Given this list of marker genes FAM78A, DLC1, VDR, ID1, IGFBP4, SH3BP2, TRAPPC14, CHST11, CDK17, CRTC3, AGAP3, STX6, COQ2 (coenzyme Q2, polyprenyltransferase), ZNF710, GNB4, BRPF3, RUNX3, TMCC3, FURIN, TNFAIP8L1, TLE3, MAPKAPK5-AS1, DCBLD1, NFKBIE, PLEKHO2, TYRO3, SMURF2, ELL2, ENG, HIVEP3, TOR4A, TLR1, KCNMB1, ZNF691, SPAST, PIK3C2B, BCOR, TBC1D16, ZSWIM6, SWAP70, ITPKB, SLC22A4, PMEPA1, CBFB, SAMD1, MYO1F, S100A10, FLOT1, SERTAD1, UAP1, RYBP, RIN3, SSH1, GAL3ST4, RELT, SLCO2B1, INPP5A, RASSF5, C10orf95-AS1, GNA13, PSME4, KCNN4, LHFPL2, IL21R-AS1, KDM7A, SLC25A19, IDS, ANGPTL4, PLEKHA7, LAT2, RFX2, VASH1, SKI, CEBPA, MAP1S (microtubule associated protein 1S), CD58, DNASE2, PMPCA, XPOT, CRACDL, ARAP3, SFMBT2 (Scm like with four mbt domains 2), MIR23AHG, TGIF1, MEF2A, FMNL3, CERK, HAVCR2, RGS1, IER5L, NRIP1, TSKU, THBS1, CALHM2, BLMH, NOTCH1, GRB10, SLC46A2, SEMA4B, ARHGEF40, GTF2IRD1, FAM53B, IER2, SLC16A6, ITGA5, SMAD7, ID3, SIGLEC9, SERPINE1, JUNB, ITPRIPL2, TNFRSF12A, ARF6, CAMSAP1, CCDC9B, SLC7A7, LPIN2, MAST3, BTG1, RNF168, KCTD10, OLR1, PLK3, RUNX2, BMPR2, GPR157, TMEM51, TMEM52B, ISCU, SLX4, OTULIN, TRIM36, CYP19A1, ITGAV (NCBI Gene Id 7449), SLC43A2, ZMIZ1, MIR155HG, TMEM223, DUSP1, NEK6, ICOSLG, REST, DESI2, SPIN1, IER3, CXCR4, RGS19, HMOX1, SH3BP4, GPRIN3, SOCS6, RNF166, RFFL, JPT1, RASGEF1B, FHOD1, ZBTB4, MAEA, SKIL, WNT5A, NCOR2, MORC3, TFEB, CXXC5, LFNG, MAP3K2, DENND3, KLF10, NFKBIA, CHD9, PHC2, ELF4, LCP2, LIMS1, SH3GL1, SH3TC1, RCC2, YWHAH, STK40, CEP170 (centrosomal protein 170), NOL4L, LINC-PINT, SPIN4, ID2, MOAP1 (modulator of apoptosis 1), FBXL14, FHL3, NCOA4, BLOC1S2, FAM120AOS, ELK3, APBB1IP, SMAD6, MMP2, SLC7A5, ZRANB1, IRF2BPL, VSIG10L, here is a description of the gene set: Human Gene Set: GSE16266_CTRL_VS_LPS_STIM_MEF_UP To clarify inflammatory genes whose expression is suppressed at high temperatures, we performed comprehensive analysis of gene expression by using a DNA microarray. Two independent primary cultures of mouse embryo fibroblasts (MEF1 and MEF2) were treated with LPS for 4 hours, or treated with LPS for 4 hours after the pretreatment with heat shock at 42˚C for 1 hour, and we identified genes that undergo more than a 3-fold increase with LPS treatment. Remarkably, genes (86%) underwent less than a 2-fold increase after combined treatments with heat shock and LPS in MEF1 and MEF2 cells. species: Homo sapiens Genes up-regulated in mouse embryonic fibroblasts (MEF): control versus LPS. from publication Takii R, Inouye S, Fujimoto M, Nakamura T, Shinkawa T, Prakasam R, Tan K, Hayashida N, Ichikawa H, Hai T, Nakai A (PMID 20018623)